Given this list of marker genes Brsk1, Snap91, App, Cacna1d, Grip1, Cacna2d3, Gria1 (NCBI Gene Id 72995), Hcn1, Unc13b, Slc32a1, Iqsec2, Slc17a7, Dgki, Grin3b, Kctd8, Vps11, Grm3, Trio, Atp2b1, Adora2a, Napb, Stx2, Erc2, Gad1, Ntrk2, Nptn, Ppfia4, Ntng2, Afdn, Gabra2, Stx1a, Otof, Ppfia3, Cntnap1, Dao, Stx1b, Grin1, Scn8a, Ctnnd1, Arfgap3, Tenm3, Syt1, Osbpl2, Adra2a, P2rx2, Kctd12, Cd200, Gria2, Ctbp1, Grm7, Gper1, Grm4 (glutamate receptor, metabotropic 4), Nrxn3, Zzef1, Rims2, Grin2b, Ctnna2, Nrg1, Ctnnb1, Kctd12b, Rims1, Gpm6a, Kcnj8, Shank2, P2ry1, Tprg1l, Lpar2, Snap47, Cacna2d1, Rimbp2 (RIMS binding protein 2), Celsr3, P2ry4, Gabrb1, Gucy1b1 (guanylate cyclase 1, soluble, beta 1), Ppfia1, Sv2a, P2ry2, Napa, Phb2, Erc1, Cacna1h, Atp2b4, Grin2d, Egflam, Gria4, Pnisr, Ctbp2, Ehd1, Cntnap2, Syn1, Grm8, Nufip1, Nr3c2, Ntng1, Adora1, Nrxn1 (neurexin I), Gabra3, Snap25, Cdh10, Flot1, Adcy8, Stxbp1, Cacna1a, Trappc4, Stx11, Unc13a, Pclo, Rab3a, Stx19, Gria3, Fzd3, Vdac1, Atp2b2, Gabrb2, Pi4k2a, Rock2, Kcnma1, Arhgap44, Cacna1b, Ppfibp2, P2rx1, Ppfia2, Cplx3, Ppfibp1, Lrfn3, Flot2, Rims3, Nectin1, Itga3, Phb1, Cdh2, Apba1, Syp, Ryk, Canx, C1qbp, Bsn, Syt11, Cacna2d2, here is a description of the gene set: Mouse Gene Set: GOCC_PRESYNAPTIC_ACTIVE_ZONE species: Mus musculus A specialized region of the plasma membrane and cell cortex of a presynaptic neuron; encompasses a region of the plasma membrane where synaptic vesicles dock and fuse, and a specialized cortical cytoskeletal matrix.